Given this list of marker genes Nr1h4, Apoa1, Apoc3, Apoa2, Apoa5, here is a description of the gene set: Any process that modulates the rate, frequency or extent of very-low-density lipoprotein particle remodeling. Very-low-density lipoprotein particle remodeling is the acquisition, loss or modification of a protein or lipid within a very-low-density lipoprotein particle, including the hydrolysis of triglyceride by hepatic lipase or lipoprotein lipase and the subsequent loss of free fatty acid. species: Mus musculus Mouse Gene Set: GOBP_REGULATION_OF_VERY_LOW_DENSITY_LIPOPROTEIN_PARTICLE_REMODELING